Given this list of marker genes PARP2, CHD1L, MACROH2A1, HTATSF1, CGAS, here is a description of the gene set: species: Homo sapiens Human Gene Set: GOMF_POLY_ADP_D_RIBOSE_MODIFICATION_DEPENDENT_PROTEIN_BINDING Binding to a protein upon poly-ADP-ribosylation of the target protein.